The following is a description of a gene set: Human Gene Set: KEGG_MEDICUS_REFERENCE_CCR_CXCR_GNB_G_PI3K_RAC_SIGNALING_PATHWAY species: Homo sapiens CCR/CXCR-GNB/G-PI3K-RAC signaling pathway. Pathway ID: N00153. Pathway type: Reference. Pathway class: nt06224 CXCR signaling. Pathway Definition from KEGG: (CC,CXC) -> (CCR,CXCR) -> GNB/G -> PI3Kgamma -> PREX1 -> RAC1, and this is the list of marker genes: CCR3, RAC1, GNB3, GNGT1 (NCBI Gene Id 2792), GNG12, CCR8, GNG5, GNB2, GNB1, PREX1, PIK3CG, GNG7, CCR4, PIK3R5, GNG13, CCL1, CXCL8, GNG3, GNG10, GNB5, CCL3, GNG4, PIK3R6, GNG11 (G protein subunit gamma 11), GNGT2, CXCR2, CCL2, CCL4, GNB4, GNG2, GNG8